The following is a description of a gene set: Any process that stops, prevents, or reduces the frequency, rate, or extent of smooth muscle cell apoptotic process. Human Gene Set: GOBP_NEGATIVE_REGULATION_OF_SMOOTH_MUSCLE_CELL_APOPTOTIC_PROCESS species: Homo sapiens, and this is the list of marker genes: MAP2K5 (mitogen-activated protein kinase kinase 5), ESR1, MIR138-1, MIR17, STUB1, APOH, NR4A3, MAPK7, GRIA4, MIR21, LRP6, DNMT1, IGF1, MIR92A1, DIPK2A, MIR210, SLC7A5, LYPD3, EDN1